Given this list of marker genes Notch1, Lhx5, Olig2, Cln8, Gsx1, Wnt1, Gdpd5, Sox13, Hoxd10, Dmrt3, Dync2h1, Tctn1, Isl1, Lbx1, Ascl1, Foxn4, Lmo4, Lhx1, Phox2a, Nkx2-2, Zc4h2, Gdf7, Mir92-1, Isl2, Mir20a, Nkx6-2, Gli3, Ift172 (NCBI Gene Id 67661), Nfe2l1, Draxin, Cacna1a, Sox6, Gata2, Evx1, Dll4 (NCBI Gene Id 54485), Gli2, Gsx2, Scyl3, Wnt3a, Mir17, Lonrf2 (NCBI Gene Id 98460), Scyl1, Olig3, Pax7, Gbx1, Mnx1, Dicer1, Tbx20, Pax3, Abt1, Shh, Lhx1os, Dbx1, Tal1, Lhx3, Lhx4, Ptch1, Sox1, Gigyf2, Ighmbp2, Mir18, Mir19b-1, Hoxc10, Sufu, Mir19a, Nkx6-1, Pax6, here is a description of the gene set: studied in species Mus musculus The process in which relatively unspecialized cells acquire specialized structural and/or functional features that characterize the cells of the spinal cord. Differentiation includes the processes involved in commitment of a cell to a specific fate. Mouse Gene Set: GOBP_CELL_DIFFERENTIATION_IN_SPINAL_CORD